The following is a description of a gene set: species: Homo sapiens Human Gene Set: GOBP_CELL_DIFFERENTIATION_INVOLVED_IN_PHENOTYPIC_SWITCHING A cell differentiation process that is a part of a reversible switch of a cell from one cell type or form to another, at a frequency above the expected frequency for somatic mutations., and this is the list of marker genes: MIR18A, SOD2, FGF9 (NCBI Gene Id 2254), DNMT1, MIR140